The following is a description of a gene set: Mouse Gene Set: GOBP_GLOSSOPHARYNGEAL_NERVE_DEVELOPMENT studied in species Mus musculus Various sensory and motor branches of the glossopharyngeal nerve supply nerve connections to the pharynx and back of the tongue. The branchial motor component contains motor fibers that innervate muscles that elevate the pharynx and larynx, and the tympanic branch supplies parasympathetic fibers to the otic ganglion., and this is the list of marker genes: Hoxa3, Hoxd3, Hoxb3, Nav2, Plxna4